The following is a description of a gene set: Genes predicted to be targets of miRBase v22 microRNA hsa-miR-6877-3p in miRDB v6.0 with MirTarget v4 prediction scores > 80 (high confidence targets). from publication Chen Y, Wang X (PMID 31504780) studied in species Homo sapiens Human Gene Set: MIR6877_3P, and this is the list of marker genes: FBXW7, UBN2, CAPZA1, CDKN2B, NPY2R (neuropeptide Y receptor Y2), SRSF10, FEZF2, ARHGAP32, LRPAP1, LMNA, LRBA, RALGPS1, SYNJ1, RABGEF1 (RAB guanine nucleotide exchange factor 1), ADGRG2, LRIG1, MRC2, DNM3, LYN, VCF1, UBE4A, CNTF, YWHAE, NPEPPS, C2orf49, RCAN1, KLF6, GLUD1, NEDD9, ATP6V1F, LHX2, KBTBD2, NCR3LG1